The following is a description of a gene set: Human Gene Set: HP_NONKETOTIC_HYPOGLYCEMIA studied in species Homo sapiens Nonketotic hypoglycemia, and this is the list of marker genes: GFRA1, MEN1, ACADVL, RET, HMGCL, AKT2, ACAD9, FGF20, ITGA8, WNT9B, CPT2, GREB1L, YY1